The following is a description of a gene set: studied in species Homo sapiens Binding to a member of the MDM2/MDM4 protein family, comprising negative regulators of p53. Human Gene Set: GOMF_MDM2_MDM4_FAMILY_PROTEIN_BINDING, and this is the list of marker genes: RFWD3, TP63, PSME3, PPARA, CDK5RAP3, RPS15, RPL37, TP73, CDKN2A, TP53, MARCHF7 (NCBI Gene Id 64844), RPS20